The following is a description of a gene set: studied in species Homo sapiens Human Gene Set: HP_DECREASED_MINIATURE_ENDPLATE_POTENTIALS Decreased miniature endplate potentials An abnormal reduction in the amplitude of the miniature endplate potentials, i.e. the postsynaptic response to transmitter released from an individual vesicle at the neuromuscular junction., and this is the list of marker genes: AGRN, CHRND, LRP4, CHRNA1, CHAT, COL13A1, RAPSN (receptor associated protein of the synapse), CHRNB1, MUSK, AK9, DOK7, CHRNE, SCN4A